The following is a description of a gene set: species: Mus musculus Cytokines mediate cell-cell communication in the immune system and represent important therapeutic targets. A myriad of studies have highlighted their central role in immune function, yet we lack a global view of the cellular responses of each immune cell type to each cytokine. To address this gap, the authors created the Immune Dictionary, a compendium of single-cell transcriptomic profiles of more than 17 immune cell types in response to each of 86 cytokines (>1,400 cytokine-cell type combinations) in mouse lymph nodes in vivo. A cytokine-centric view of the dictionary revealed that most cytokines induce highly cell-type-specific responses. For example, the inflammatory cytokine interleukin-1β induces distinct gene programmes in almost every cell type. A cell-type-centric view of the dictionary identified more than 66 cytokine-driven cellular polarization states across immune cell types, including previously uncharacterized states such as an interleukin-18-induced polyfunctional natural killer cell state. Mouse Gene Set: CUI_PDC_IL2_RESPONSE_DN Genes negatively differentially expressed in cell type: pDC (plasmacytoid dendritic cell) upon treatment with cytokine: IL-2 in mouse lymph nodes in vivo. from publication Cui A, Huang T, Li S, Ma A, Pérez JL, Sander C, Keskin DB, Wu CJ, Fraenkel E, Hacohen N (PMID 38057668), and this is the list of marker genes: Tsc22d3, Klhl24, Mrpl30, Jun (NCBI Gene Id 16476), Fos, Ubc, H3f3b, Ypel3, Klf2, Eef2, Ramp1, Cmah, Btg2, Ap3b1, Ubb, Pik3ip1, Arl5c, Rgs1, Cdip1